Given this list of marker genes ENPP1, MIR208A, HIF1A, RFLNA, AHSG, CCR1, GATA1, PTK2B, PTH, SRGN, CCL3, FGF23, LTBP3, GREM1, RFLNB, TRPM4, BCOR, ECM1, SOX9, STATH, here is a description of the gene set: Any process that stops, prevents, or reduces the frequency, rate or extent of bone mineralization. studied in species Homo sapiens Human Gene Set: GOBP_NEGATIVE_REGULATION_OF_BONE_MINERALIZATION